The following is a description of a gene set: Sterol regulatory element binding proteins (SREBPs, SREBFs) respond to low cholesterol concentrations by transiting to the nucleus and activating genes involved in cholesterol and lipid biosynthesis.<br> Newly synthesized SREBPs are transmembrane proteins that bind SCAP in the endoplasmic reticulum (ER) membrane. SCAP binds cholesterol which causes a conformational change that allows SCAP to interact with INSIG, retaining the SCAP:SREBP complex in the ER. INSIG binds oxysterols, which cause INSIG to bind SCAP and retain SCAP:SREBP in the endoplasmic reticulum.<br>In low cholesterol (below about 5 mol%) SCAP no longer interacts with cholesterol or INSIG and binds Sec24 of the CopII coat complex instead. Thus SCAP:SREBP transits with the CopII complex from the ER to the Golgi. In the Golgi SREBP is cleaved by S1P and then by S2P, releasing the N-terminal fragment of SREBP into the cytosol. The N-terminal fragment is imported to the nucleus by importin-beta and then acts with other factors, such as SP1 and NF-Y, to activate transcription of target genes. Targets of SREBP include the genes encoding all enzymes of cholesterol biosynthesis and several genes involved in lipogenesis. SREBP2 most strongly activates cholesterol biosynthesis while SREBP1C most strongly activates lipogenesis. studied in species Homo sapiens part of: Metabolism of steroids Reactome Pathway: Regulation of cholesterol biosynthesis by SREBP (SREBF), and this is the list of marker genes: TBL1X, SCAP, MTF1, NFYC, GGPS1, SEC24C, TM7SF2, MBTPS2, HELZ2, HMGCS1, DHCR7, SMARCD3, SREBF2, RAN, RXRA, NFYB, HMGCR, ACACA, CHD9, NCOA2, LSS, MVD, SEC24D, FDFT1, NCOA1, SP1, FDPS, TBL1XR1, MVK, INSIG1, MED1, GPAM, SQLE, TGS1, PMVK, SREBF1, SEC24B, IDI1, SC5D, SCD, ELOVL6, SEC23A, CYP51A1, INSIG2, MBTPS1, FASN, CREBBP, NFYA, PPARA (peroxisome proliferator activated receptor alpha), CARM1 (NCBI Gene Id 10498), ACACB, KPNB1, SAR1B, SEC24A, NCOA6